The following is a description of a gene set: species: Homo sapiens Human Gene Set: GOBP_STEROL_HOMEOSTASIS Any process involved in the maintenance of an internal steady state of sterol within an organism or cell., and this is the list of marker genes: SIRT1, PCSK9, MYLIP, LDLRAP1, MIR144, HDAC9, GPIHBP1, APOA4, CYP7B1, HSDL2, ABCG5, TSPO, SOAT2, SOAT1, NFE2L1 (NCBI Gene Id 6937), MIR208A, APOE, PNLIPRP3, SCARB1, RORA, LIMA1, ANGPTL3, PLA2G10 (NCBI Gene Id 8399), FABP3, PLSCR3, DISP3, MIR185, NR1H3, ABCG1 (NCBI Gene Id 9619), MIR590, RALY, LDAH, NR1H2, AMPD2, MIR182 (NCBI Gene Id 406958), NPC1L1, LDLR, ACSM1, APOC3, CNBP, LIPC, APOA2, ACSM3, APOC2, CETP, EHD1, G6PC1, MIR148A, MIR128-1, MINAR2, NR1D1, HNF4A, NPC2, TSKU, ABCA5, EPHX2, CES1, PNLIPRP1, ABCD1, COMMD1, NR5A2, MALRD1, NPC1, NEGR1, COMMD9, ABCG8, APOB, AKR1C1, LAMTOR1, FGFR4, ERRFI1, ACOX1, CAV3, XBP1, DGAT2, CAV1, INSIG1, APOA5, CYP39A1, CD24, LPL, MIR302A, MALL, MIR27B, PLA2G12B, LCAT (NCBI Gene Id 3931), PNLIPRP2, GRAMD1B, LRP5, TMEM97, MTTP, SEC24A, MIR30C1, APOM, PNLIP, MIR33B, TTC39B, FABP4, MIR132, SREBF2, MIR19B1, IL18, LIPG, ABCB11, NUS1, ABCG4, ABCA2, MED13, MIR34A, CYP7A1, ABCA1, APOA1, NR1H4